The following is a description of a gene set: Mouse Gene Set: GOMF_LIGAND_GATED_MONOATOMIC_ANION_CHANNEL_ACTIVITY Enables the transmembrane transfer of an inorganic anion by a channel that opens when a specific ligand has been bound by the channel complex or one of its constituent parts. studied in species Mus musculus, and this is the list of marker genes: Ano9, Chrm5, Cftr, Ano3, Gabrg3, Gabra4, Gabrr1, Gabrg1, Ano2, Best3, Ano10, Clca4a, Pacc1, Clca3b (NCBI Gene Id 229927), Gabrq, Ano1, Gabra3, Gabre, P2rx5, Best1, Nmur2, Ttyh1, Ttyh3, Gabra5, Gabra6, Glra3, Aqp6, Best2, Glrb, Gabrb2, Clca1, Gabra2, Clca4b, Glra4, Ano4, Gabra1, Ano6, Ano7, Ttyh2, Gabrr2, Glra1, Gabrb1, Gabrp, Slc1a7, Clca3a2, Clca3a1, Ano8, Ano5, Slc17a7, Gabrb3, Clca2, Glra2, Gabrg2